Given this list of marker genes TNFSF9, NFIL3, FGFR1OP2 (FGFR1 oncogene partner 2), CXCL8, GNA13, SAMSN1, UBE2FP1, PHF1, STK17A, N4BP2L2, BANP, ZNF394, SRXN1, HSPB8, CXCL3, FRS2, ZFAND2A, HSPH1, KIF1B, SERTAD1, RELB, OSER1, MACO1, KDM7A, EID3, MIR4458HG, MTHFD2L, NFATC2, KCTD5, BACH1, ZNF222 (zinc finger protein 222), KITLG, TRIB1, PLAUR, TMEM217, RCAN1, PPP3CC, VCPIP1, SAV1, INHBA, DNAJA1, PCF11, GPAT3, HSPA1B, RHEBL1, BRF2, ZNF264, SOS1, HERPUD1, DNAJA4, BAG3, RBBP6, ZBTB21, PNPLA8, TSC22D3, KLHL21, HSPA4L, MAP1LC3B, YRDC, RAB23, RRP7A, CREM, F3, DNAJB6, MOSMO, C10orf88, AKIRIN2, CWC25, HAPSTR1, HSPA1A, RNF24, LURAP1L, DNAJB9, SLC3A2, RELN, AHSA1, DEDD2, HBEGF, RBM33, RYBP, KIF21A, JUND, SLC19A2, RGMB, AGO2, RORA, CNST, CPEB4, GLA, SPIRE1, SMCR8, E2F6, SMURF1, VPS37A, ZBTB43, PNP, ESM1, IFRD1, FOSL1 (FOS like 1, AP-1 transcription factor subunit), KBTBD8, KLF5, CCNG2, MAFK, DDIT3, STIP1, ZNRF3, MILIP, SOWAHC, JMJD6, DNAJB1, CBLL1, MXD1, ATF3, EIF5, UBALD2, HSPA6, CASP3, NUTM2B-AS1, RTCA, ZNF473, PCYT1A, AIFM2, PXDC1, CHORDC1, EMP1 (epithelial membrane protein 1), PMAIP1, MIR22HG, AMMECR1L, CREBBP (NCBI Gene Id 1387), RSL1D1, KLHL28, ZC3H12C, KANSL1L, MIR3682, SESN2, ZNF468, SPINDOC, WDR20, MAFG, here is a description of the gene set: species: Homo sapiens Human Gene Set: GARGALOVIC_RESPONSE_TO_OXIDIZED_PHOSPHOLIPIDS_BLUE_UP from publication Gargalovic PS, Imura M, Zhang B, Gharavi NM, Clark MJ, Pagnon J, Yang WP, He A, Truong A, Patel S, Nelson SF, Horvath S, Berliner JA, Kirchgessner TG, Lusis AJ (PMID 16912112) Genes from the blue module which are up-regulated in HAEC cells (primary aortic endothelium) after exposure to the oxidized 1-palmitoyl-2-arachidonyl-sn-3-glycerophosphorylcholine (oxPAPC). Oxidized phospholipids are thought to promote atherogenesis by stimulating endothelial cells (ECs) to produce inflammatory cytokines, such as IL-8. In studies with mouse models, we previously demonstrated that genetic variation in inflammatory responses of endothelial cells to oxidized lipids contributes importantly to atherosclerosis susceptibility. We now show that similar variations occur in cultured aortic ECs derived from multiple heart transplant donors. These variations were stably maintained between passages and, thus, reflect either genetic or epigenetic regulatory differences. Expression array analysis of aortic EC cultures derived from 12 individuals revealed that >genes were regulated by oxidized phospholipids. We have used the observed variations in the sampled population to construct a gene coexpression network comprised of 15 modules of highly connected genes. We show that several identified modules are significantly enriched in genes for known pathways and confirm a module enriched for unfolded protein response (UPR) genes using siRNA and the UPR inducer tunicamycin. On the basis of the constructed network, we predicted that a gene of unknown function (MGC4504) present in the UPR module is a target for UPR transcriptional activator ATF4. Our data also indicate that IL-8 is present in the UPR module and is regulated, in part, by the UPR. We validate these by using siRNA. In conclusion, we show that interindividual variability can be used to group genes into pathways and predict gene-gene regulatory relationships, thus identifying targets potentially involved in susceptibility to common diseases such as atherosclerosis.